The following is a description of a gene set: studied in species Homo sapiens Absence of one or more of the phalanges of the hand. Aplasia of the phalanges of the hand Human Gene Set: HP_APLASIA_OF_THE_PHALANGES_OF_THE_HAND, and this is the list of marker genes: LMBR1, BMPR1B, NSDHL, LMNA, VAC14, SHH, FGFR2, FANCD2, TRIO, TBX5, IFT140, ATP6V1B2, GJA1, XRCC2, FIG4, MEGF8